The following is a description of a gene set: Human Gene Set: MIR3663_5P Genes predicted to be targets of miRBase v22 microRNA hsa-miR-3663-5p in miRDB v6.0 with MirTarget v4 prediction scores > 80 (high confidence targets). from publication Chen Y, Wang X (PMID 31504780) studied in species Homo sapiens, and this is the list of marker genes: POLR2D, RBM20, TMEM168, NRSN1, RAD21, EPB41L2, VAPA, ATP2B4, EPN2, LIN28A, SH3TC2, SELENOT, RSBN1, CD4, SLC11A2, G3BP2, PHYKPL, CBFB, REEP1 (NCBI Gene Id 65055), BTRC, SYNJ2BP, YBX1, MEIS2, NFE2, INSYN2B, ARL6IP1, NFIB, C1orf94, VASH1, PALM2AKAP2, RAD9A, EVC, SORBS3, NPTX1, EML5, GRIK3, PLEC, PAN3, KLK10, KCNN3, TBL1X, TMEM184B, MANEA, FER, KCNK10, ADPRHL1, SMARCE1, BAZ2B, NAT9, TMPO, MXRA7, XYLT1, TBC1D12